The following is a description of a gene set: studied in species Homo sapiens Human Gene Set: REACTOME_SEROTONIN_AND_MELATONIN_BIOSYNTHESIS Serotonin and melatonin biosynthesis, and this is the list of marker genes: AANAT, DDC, TPH1, TPH2, ASMT